Given this list of marker genes CCR4, GPR18, CTSW, SLC4A10, CST7, MS4A1, KLRC4-KLRK1, IL23R, CD79A, CD247 (NCBI Gene Id 919), SH2D1A, MYO1G, CCR7, PTGDR2, SKAP1-AS1, SLFN12L, GZMM, CD160, EOMES, SLFN13, CHI3L2 (NCBI Gene Id 9155), LINC01871, SEPTIN1, IL26, TRBC2 (T cell receptor beta constant 2), IL12RB2, TMIGD2, GNLY, LINC00426, CRTAM, FASLG, CD40LG, CD52, ACAP1, NMUR1, CD3D, ZNF385C, NCR1, IKZF3, SIT1, CD2, LINC02384, CD3E, TESPA1, LINC01221, SLA2, SPINK2, ZBTB16, SHISAL2A (shisa like 2A), CD6, KRT81, GPR68, CXCR3, UBASH3A, NT5C3AP2, CD3G (CD3 gamma subunit of T-cell receptor complex), TCL1A, LTB, ENSG00000266088, KLRF2, ITK, LINC01215, TSPOAP1-AS1, TRAT1, VPREB3, CXCR6, NCR2, COL4A4, GZMA, VPREB1, ZAP70 (NCBI Gene Id 7535), SH2D2A, TNFRSF18, IL2RA, PLEKHF1, CD96, CARD11, LZTFL1, KLRC1, NCR3, GATA3 (GATA binding protein 3), LINC02481, NLRC3, SCML4, IL4I1 (interleukin 4 induced 1), LTA, THEMIS, TBX21, GBP5, DENND2D, PTPRCAP, IL17A, MANEA-DT, TRGC2, JMY (junction mediating and regulatory protein, p53 cofactor), LINC01891, IL18RAP, TNFSF11, RGL4, PDE7A, IL2RB, BLK, AOX2P, IKZF2, SLAMF6, PTPN22 (protein tyrosine phosphatase non-receptor type 22), KLRK1, KLRB1, LINGO4 (NCBI Gene Id 339398), SLAMF1, TBC1D10C, LINC01934, IGHD, TXK, CD8A, LY9, KLRC2, STAT4, KLRD1, LCK, NKG7, TRGC1, SYTL1, IL2RG (NCBI Gene Id 3561), TCF7, DTHD1, PTPN7, GZMK, CD69, KRT86, SH2D1B, PRF1, LINC00892, CD79B, SKAP1, PTGDR, ITGAE, KLRC3, CXCR5, KIT, XCL1, MATK, LINC00299, CCR9, TRDC, ENSG00000261448, STAP1, LAX1, IL1RL1, ICOS, ALDOC, ENSG00000259097, LINC02726, GPR171, IGHM (immunoglobulin heavy constant mu), PAX5, S1PR4, PCED1B-AS1, CD5, SIRPG, IGLL1, CD7, IL21R, IL7R, LINC01222, PYHIN1, here is a description of the gene set: The gene expression program underlying the specification of human cell types is of fundamental interest. The study authors generated human cell atlases of gene expression and chromatin accessibility in fetal tissues. For gene expression, the study authors applied three-level combinatorial indexing to >110 samples representing 15 organs, ultimately profiling ~4 million single cells. The study authors leveraged the literature and other atlases to identify and annotate hundreds of cell types and subtypes, both within and across tissues. Our analyses focused on organ-specific specializations of broadly distributed cell types (such as blood, endothelial, and epithelial), sites of fetal erythropoiesis (which notably included the adrenal gland), and integration with mouse developmental atlases (such as conserved specification of blood cells). These data represent a rich resource for the exploration of in vivo human gene expression in diverse tissues and cell types. Human Gene Set: DESCARTES_FETAL_INTESTINE_LYMPHOID_CELLS from publication Cao J, O'Day DR, Pliner HA, Kingsley PD, Deng M, Daza RM, Zager MA, Aldinger KA, Blecher-Gonen R, Zhang F, Spielmann M, Palis J, Doherty D, Steemers FJ, Glass IA, Trapnell C, Shendure J (PMID 33184181) Marker genes curated from the annotated cluster as represented in the Descartes Human Gene Expression During Development database. species: Homo sapiens